The following is a description of a gene set: Genes encoding structural ECM glycoproteins from publication Naba A, Clauser KR, Hoersch S, Liu H, Carr SA, Hynes RO (PMID 22159717) Human Gene Set: NABA_ECM_GLYCOPROTEINS species: Homo sapiens One hallmark of ECM proteins is their domain-based structure. Exploiting this characteristic, we established a list of diagnostic InterPro domains commonly found in ECM proteins. We know that some of the domains used to select positively for ECM proteins are also found in transmembrane receptors and proteins involved in cell adhesion (growth factor receptors, integrins, etc) that do not belong to the ECM. These families of proteins also display a subset of specific domains and transmembrane domains incompatible with definition as “extracellular matrix” proteins. Therefore, a second step comprised a negative selection using another set of domains and a transmembrane domain prediction. Manual curation of the matrisome lists also allowed us to add a very few known ECM proteins that do not contain any known domains. Protein-centric predictions were then converted to gene-centric lists. Finally, knowledge-based annotation of these gene lists allowed us to define subcategories within the core matrisome; namely, ECM glycoproteins, collagens, and proteoglycans. We also defined separate lists of domains commonly found in 1) ECM-affiliated proteins (proteins that share either some architectural similarities with ECM proteins or that are known to be associated with ECM proteins; 2) ECM regulators: ECM-remodeling enzymes, crosslinkers, proteases, regulators etc.; 3) secreted factors, many of which are known to bind to ECM and others that may. As for the core matrisome list, we also defined lists of domains that excluded mis-assigned proteins from these categories. Using similar bioinformatic pipelines as for the core matrisome, we defined three categories of “matrisome-associated” proteins: ECM-affiliated proteins, ECM regulators, and secreted factors., and this is the list of marker genes: ECM2, SRPX2, SPON1, TINAGL1, KCP, IGFBP6, ADIPOQ, OTOG, MXRA5, PAPLN, SLIT2, ELN (NCBI Gene Id 2006), LAMA4, ZP1, RSPO4, EDIL3, VWF, LAMB4, EYS, SPARCL1, EMID1, LAMB3, FGB, VWA1, VTN, NTN1, DMBT1, COLQ (collagen like tail subunit of asymmetric acetylcholinesterase), EMILIN3, GAS6, CDCP2, DPT, VWA3B, MMRN2, SPP1, LTBP2, LAMA2, PXDN, ANOS1, EMILIN1, IGFBP5, IGFBPL1, CILP, SMOC2, VWA3A, IGFBP7, INTS6L, FGL1, AMELY, SLIT3, HMCN1, VWA7, IGFBP4, HMCN2, POMZP3, SMOC1, MFAP1, LTBP1, MATN1 (NCBI Gene Id 4146), CRIM1, SPON2, ZPLD1, IGFBP2, FRAS1, MFAP5, NDNF, FNDC8, THBS3, LAMA1, NTN4, FBLN1, POSTN, TECTA, TSPEAR, COMP, BGLAP, NELL1, TSKU, CRELD1, CRELD2, IBSP, BSPH1, DMP1, CCN4 (NCBI Gene Id 8840), BMPER, TECTB, FNDC7, FBN2, FN1, LGI1, THSD4 (NCBI Gene Id 79875), LAMC1, TNN, FBN3, PCOLCE2, AMBN (ameloblastin), LAMC2, SSPOP, NID2, CCN2, LGI3, PCOLCE, TNFAIP6, ECM1, TINAG, CRISPLD2, USH2A, AMELX, IGSF10, LTBP3, RELN, NPNT, VWA5B1, INTS14, PXDNL, FNDC1, FBLN7, LRG1, FBN1, OTOL1, LGI2, ELSPBP1, ABI3BP, MGP, LAMC3, NELL2, ZP3, MATN2 (NCBI Gene Id 4147), CCN6, GLDN, FBLN2, EGFLAM, NTN3, MEPE, MFAP4, CCN1, FGA, MFAP2, EMILIN2, LAMA3, THBS4, CCN5, NID1, SVEP1, DSPP, IGFALS, MATN3, VWA2, CCN3, MATN4, EFEMP1, FBLN5, LAMB2, AEBP1, TNR, ZP4, VWA5A, CTHRC1, SNED1, THBS2, COCH, VWCE, SRPX, RSPO3, VIT, THBS1, LAMB1, LGI4, OIT3, IGFBP1, FGG, CRISPLD1, TGFBI, FGL2, LAMA5, MFAP3, AGRN, VWDE, SBSPON, CILP2, ZP2, TNXB (NCBI Gene Id 7148), MFGE8, VWA5B2, NTNG1, SPARC, MMRN1, LTBP4, TNC, IGFBP3, RSPO2, NTNG2, NTN5, SLIT1, RSPO1, EFEMP2